The following is a description of a gene set: Genes predicted to be targets of miRBase v22 microRNA hsa-miR-5588-3p in miRDB v6.0 with MirTarget v4 prediction scores > 80 (high confidence targets). Human Gene Set: MIR5588_3P from publication Chen Y, Wang X (PMID 31504780) species: Homo sapiens, and this is the list of marker genes: ABI1, RSRC2, GNAI3 (G protein subunit alpha i3), RANBP3, LRRFIP1, NXF1 (NCBI Gene Id 10482), LILRA4, COX4I1, OSTM1, SEPTIN8, LRIF1, DVL2, DCAF12, SEC62, PIK3R1, HBEGF, ZFP36L1, CNEP1R1, PICALM, CPT2, ATP11B, TPT1, GABRR1, TPH2, NREP, POGLUT3 (protein O-glucosyltransferase 3), GLUL (NCBI Gene Id 2752), GPR137C, GRID2, CHMP5, CNKSR2, SLC25A5 (solute carrier family 25 member 5), SUV39H2, SEH1L, PTPRD, IL7R, ZBTB14, MEGF8, E2F5, SECISBP2L, SYT6, BZW2 (basic leucine zipper and W2 domains 2), MED13L, DLX5, CCDC6